The following is a description of a gene set: Mouse Gene Set: WP_CYTOKINES_AND_INFLAMMATORY_RESPONSE Cytokines and inflammatory response species: Mus musculus, and this is the list of marker genes: Tgfb1, Il12a, Il10, Ifna1, Il3, Cxcl3, Il6, Il7, Il5, Cxcl1, Il12b, Ifnb1, Csf1, Il4, Il15, Il1a, Il11, Tnf, Csf2, Pdgfa, H2-Eb1 (NCBI Gene Id 406211), Ifng, Il2 (interleukin 2), Il13, Il1b, Cd4, Csf3